Given this list of marker genes Clcn6, Plekha1, Dmtf1, Ky, Btrc, Vsx2, Dact3, Zfp609, Hsf5, Rcor2, Rin2, U2surp, Rybp, Pom121l12, Tdh, Nat8l, Sec63, Ift122, Gdnf, Sh2d2a, Tsr2, Abraxas2, Tes, Prr14l, Kcnk2, Fbxo33, Sema4d, Dchs1, Larp1b, Smad6, Uhmk1, Dbndd2, Stau2, Cplx2, Dab2ip, Rarb, Arnt2, Arrdc3, Atp6v1a, Rora, Olfml3, Slc4a8, Slc10a3, Clcn4, Gabra1, Tpi1, Fbln5, Pten, Scn4b, Mmp2, Mettl24, Vps33a, Arl16, Ubiad1, Wac, Krtap1-5, Bace1, Exd2, Itsn1, Cryba1, Tfap2a, Slc2a8, Fbf1 (NCBI Gene Id 74783), Trpm7, Bahd1, Plekhg6, Tub, Sar1a, Marcksl1 (MARCKS-like 1), Sprn, Nufip2, Fmod, Shisa7, Kcnab2, Anxa8, Exoc6b, Smarcad1, Celf1, Galnt17, Tcf12, Unc13b, Lrrtm3, Slc22a15 (solute carrier family 22 (organic anion/cation transporter), member 15), Tbc1d30, Nrp1 (NCBI Gene Id 270112), Mvb12b, Phf21a, Mfsd4b5, Cxxc4, Parp16, Slc6a4, Rab22a, Ppfia3, Il7, Trabd2b, Chl1, Cxcl2, Kif9, here is a description of the gene set: Mouse Gene Set: MIR_1231_5P species: Mus musculus Genes predicted to be targets of miRBase v22 microRNA mmu_miR_1231_5p in miRDB v6.0 with MirTarget v4 prediction scores > 80 (high confidence targets). from publication Chen Y, Wang X (PMID 31504780)